The following is a description of a gene set: Human Gene Set: HP_CONGENITAL_LARYNGEAL_STRIDOR studied in species Homo sapiens Congenital laryngeal stridor, and this is the list of marker genes: EXOSC3, SLC25A46, EXOSC9 (exosome component 9), PLP1, VRK1, NFASC, EXOSC8, AGTPBP1